Given this list of marker genes Abcd2, Skint11, Dpysl5, Sipa1, Aspm, Trim6, Suv39h2, H1f6, Ccdc121rt1, Adgra2, Bgn, 1700095A21Rik, Racgap1, Cenpi, Gm10048, 1700041C23Rik (NCBI Gene Id 67319), Sox6, Rbmy (RNA binding motif protein, Y chromosome), Gm31048, Ncoa4, 1700011B04Rik, Slc9a2, Gripap1, Prtg, Pnliprp2, 4932412D23Rik, Mbtps2, Fads6, Fgf13, 9330154J02Rik, Epb41l1, Myl10, Tfcp2, Arhgef15, Scn3a, Fbxw2, Ttll5, Ghr, Zfp72, Rab34, Col11a1, Il1rl1, Slc17a1, Pde7b, Olfm4, C7, Zfp180, Cspp1, 1700017I07Rik, 9330175M20Rik, Or5k15, here is a description of the gene set: from publication Zheng Y, Valdez PA, Danilenko DM, Hu Y, Sa SM, Gong Q, Abbas AR, Modrusan Z, Ghilardi N, de Sauvage FJ, Ouyang W (PMID 18264109) Genes down-regulated in ex-vivo colonic tissue after treatment with IL22. Mouse Gene Set: ZHENG_IL22_SIGNALING_DN Infections by attaching and effacing (A/E) bacterial pathogens, such as Escherichia coli O157:H7, pose a serious threat to public health. Using a mouse A/E pathogen, Citrobacter rodentium, we show that interleukin-22 (IL-22) has a crucial role in the early phase of host defense against C. rodentium. Infection of IL-22 knockout mice results in increased intestinal epithelial damage, systemic bacterial burden and mortality. We also find that IL-23 is required for the early induction of IL-22 during C. rodentium infection, and adaptive immunity is not essential for the protective role of IL-22 in this model. Instead, IL-22 is required for the direct induction of the Reg family of antimicrobial proteins, including RegIIIbeta and RegIIIgamma, in colonic epithelial cells. Exogenous mouse or human RegIIIgamma substantially improves survival of IL-22 knockout mice after C. rodentium infection. Together, our data identify a new innate immune function for IL-22 in regulating early defense mechanisms against A/E bacterial pathogens. studied in species Mus musculus